Given this list of marker genes Ptprr, Nrp2, Prdm14, Plvap, Il17a, Adora3, Mctp1, Robo1, Apbb1, Furin, Dock10, Il23a, Gipc1, Septin4, Ulk1, Hrg, S100a7a, Ccl21e, Lbp, Rab13, Med23 (NCBI Gene Id 70208), Spint2, Hand2, Dusp22, Tmod3, Tubb4b, Osbpl8, Shh, Jun, Gba1, Vinac1, Ednra, Astn2, Josd1, Rtn4, Vcan, Mstn, Twist1, Aspm, Tekt5, Limd1, Angpt1, Rhoj, C5ar2, Mef2c, S1pr2, Ccl9, Ctnna3, Fut9, Scrib, Ptk2b, Six2, Ttll9, Ephb3, Epha3, Capn7, Spaca9, Mpp1, Fam107a, Cfap44, Kcnq1ot1, Rab1a, Epx, Xcr1, Actn4, Lmna, Il12b, Nrg1, Flna, Hdac6, Daam2, Cadm1, Six1, Iqcn, Tmigd3, Atp7a, Slc26a5, Reck, Fscn1, Trp53inp1, Gnai1, Apc2, Il12a, Prtn3, Fcer1g (NCBI Gene Id 98395), Ephb1, Ssh1, Fpr2, Stc1, Bag4, Apoe, Trp53, Camk2a, P2ry12 (NCBI Gene Id 73058), Catsperd, Ptpn22, S1pr1, Cmklr1, Bsg, Itgam, Bmerb1, Scrt1, Megf9, Rhof (ras homolog family member F (in filopodia)), Scrt2, Stard13, Drc1, Lama3, Ccdc88a, H2bc1, Lyn, Svep1, Cort, Ccl1, Cfap210, Tbx20, Acan, Tekt4 (tektin 4), T, Spp1, Postn, Fbxo41, Pla2g3, Wnt5a, Armc12, Rfx3, Myh10, Barhl1, Cfap221, Vtn, Rap2a, Adam9, Grb10, Cdc42, BC037156, Itgb6, Kif14, Nav1, Trim32, Dnah8, Slc9b2, Tlr4, Acta2, Ptprz1, Tnf, Cdh12, Duoxa2, Il33, Tspo, Acte1, Cfap144, Sema3d (NCBI Gene Id 74345), Setd2, Fut8, Twist2 (twist basic helix-loop-helix transcription factor 2), Irgc, Plcg1 (phospholipase C, gamma 1), Cfap97d1, Rhbdf1, Sgpl1, Smpd3, Atp5f1b, Pik3cd, Nisch, Pkp2, Cfap161, AU040320, Anks1, Sell, Nus1, Epha2 (NCBI Gene Id 13836), Tpgs1, Wasl, Zmiz1, Foxj1, Ccdc125, Rsph1, Tmeff2, Flrt2, Rnh1, Trem2, Acvr1b, Nr2e1, Strip2, Rack1, Dnaja1, Stk39, Ngfr, Ccr9, Stx4a, Emilin1, Adora1, Ribc1, Itgax, Nphp4, Tekt2, Tyro3, Arhgef16, Il6st, Sulf1, Taf7l, Phpt1 (phosphohistidine phosphatase 1), Fgf20, Synj2bp, Igfbp5, Neo1, Itgb8, Ackr2, Ntrk3, Nr4a2, Tafa5, Ccl11 (C-C motif chemokine ligand 11), Plxna1, Gpr173, Gpc4, Adgrb1, Pin1 (peptidyl-prolyl cis/trans isomerase, NIMA-interacting 1), Foxp1, Mylk, Ccl24, Dicer1, Nrtn (neurturin), S2bpcox16, Top2b (topoisomerase (DNA) II beta), Ptprf, Lrg1, Efhb, Dnah10, Foxo3, Amotl1, Hnf4a, Dnaaf6rt, Plxnc1, Kif26a, Zfp703, Ston1, Onecut1 (NCBI Gene Id 52327), Crtam, Pkn2, Megf8, Cep78, P4hb, Elmo2, Nrg3 (neuregulin 3), Prkd2, Fbxo31, Celsr3, Anxa5, B4galt1, Rsph6a, Nexn, Fat1, Dapk2, Emc10, Hsd3b7, Spmip8, Adamts9, Mmp2 (NCBI Gene Id 17390), Arpc2, F11r, Celf3, Rin3, Nr2f1, Dnah12, Fkrp, Dcc, Satb2, Ccl21b, Timp1, Fgfr4, Crkl, Nexmif, Fgf17, Sox10, Atoh8, Usp45, Sun2, Wfdc6b, Barhl2, Itga9 (NCBI Gene Id 70107), Gpc3 (glypican 3), Folr1, Fbxo5, Esr2, Col18a1, Mdga2, Pi4ka, Tie1, Spag6l, Cfap54, Bmp7, Socs7, Cd300a, Retnlg, Cldn5, Itga4, Prm3, Hc, Cfap45, Bdkrb1, Pkn3, Phactr1, Cer1, Axl, Dzip1, Prkca, Vil1 (NCBI Gene Id 22349), Plxnb1, Sirt1, Limch1, Actg1, Ptn, Knstrn, Mmrn2, Cxcl11, Dpep1, Cckar (NCBI Gene Id 12425), Ctnnd1, Mgat3, Pcm1, Actc1, Tek, Zpld2, Hexb, Slit2, Tnr, Kctd13, Asb2, Coro6, Arhgdia, Ntng2, Ptk6, Fndc3b, Dnah2, Gsk3b, Tuba1a, Ext1, Acvr1, Mapt, Ube2i, Cldn13, Sun1, Ptp4a1, Ric8a, Ptprc, Elp6, Nedd9, Jmy, Tesk1, Ptprt, Catsper1, Prkce, Rarres2, Tnfrsf18, Rapgef3, Ppp2r3a, Enah, Retn, Tssk4, Tekt3, Defb47, Fat3, Spmip5, Tpm1, Swap70, Flt4, Ada, Cygb, Ccn4, Mtch2, Eomes, Cldn7, Dydc1, Bst1, Dnaaf4, Alox5, Parva, D130043K22Rik, Myo9b, Spi1, Edn2, Cenpv, Mapk8ip3, Prox1, Il18, Gata2, Rbbp4, Clec14a, Csf1, Ccl19, Unc5c, Vsir, Hmox1, Ddit4, Vstm4, Hhipl1, Adtrp, Bex4, Dusp1, Gnrh1, Ttbk2, Edn3, Adam8, Casp8, Spag9, Ptprk, Nck2, Chst4, Gbf1, Rgcc, Plec, Fermt3, Cfap69 (NCBI Gene Id 207686), Wwc1, Vhl, Fcgr3, Adamts12, Adgra2, Rgn, Spem3, Mir124a-1hg, Srcin1, Tcp11l2, Zfp950, Msx2, Map2k1, Tmf1, Sema5a, Elp3, Sh2b1, Abr, Itga2b, Tubb2a, Pdcl2, Ccdc159, Htr6, Pex2, Gja1, Ajuba, Net1, Cfap126, Cfap95, Rhoa, Defb1, Ogdh (NCBI Gene Id 75674), Filip1, 2610005L07Rik, Map3k7, Ascl2, Il17b, Mir218-2, Cd63, Cripto, Lama4, Sdc1, Dnah6, Abcc8, Dnah11, Usp9y, Coro1a, Cxcr4, Sema4d, Wasf2, Gpx1, Asap3, Shroom2, Tmem18, C2cd6, Dixdc1, Ang6, Vcam1, Vav2, Sh3bp1, Inpp5f, Egfr, Hdac5, Ccl7, Bst2, S100a11, C3ar1, Pik3r1, Spinkl, Lamtor2, Camk2b, Stat5b, Pcnt, Mien1, Fadd, Plcg2, Mdga1, Clasp2, Paxip1, Pcsk5, Sdc3, Itgb7, Ribc2, Mmp28, Smim22, Hoxa7, Tlr2, Fgf21, Ttll6, Brms1l, Mark1, Mkks, Gp1ba, Fgf13, Wdr47, Tjp1 (tight junction protein 1), Ppbp (pro-platelet basic protein), Egr3, Myadm, Gm6040, Prcp, Cxcl3, Cfap43, Sema4g, Abhd6, Rras, S100a14, Ephb4, Tnfsf18, Slamf9 (SLAM family member 9), Tet1, Rabl2, Plau, Ppib, Syne2, Tfap2a, Tns3, Foxf1 (NCBI Gene Id 15227), Muc2, Fscn2, Hif1a, Wt1, Chga, Ndnf, Lrrc15, Slc9b1, Rhox5, Dab2, Cfl1, Kiss1, Cdk5r2, Cpeb1, Spmip6, Anln, Drd2, Grb7, Gdf15, Diaph1, Cspg4, Phactr4, Serpine1, Sin3a, Acp5 (acid phosphatase 5, tartrate resistant), Saa3, Nme8, Ecm1, Eng, Smo, Sirpa, Srgap1, Mtus1, Cacna1e, Catsper3, Ggt5, Src, Mcu, Tssk6, Nog, Ttll3, Coro7, Enpep, Prl7d1, Fgf16 (fibroblast growth factor 16), Patz1, Fhad1, Fignl2, Vdac3 (voltage-dependent anion channel 3), Cyp19a1, Ly6k, Spns2, Dlg5, Dnai1, Tnn (NCBI Gene Id 329278), Arc, Gsk3a, Apex1, Wdr62, Ntf3, Cers2, Smcp, Cfap251, Apod, Peak1, Fgf22, Mmp14, Arhgef5, Ezh2, Klf4, Tmprss12, Cdh13 (NCBI Gene Id 74373), Ptpru, Rbbp7, Pak1, Nsmf (NMDA receptor synaptonuclear signaling and neuronal migration factor), Insl3, Lama5, Aif1, Phb2, Robo4, Macf1, Pdgfb, Lgmn, Arid2, Mdm2, Spem1, Mysm1, Calr, Gas6, Cd44, Insm1, Defb5, Nav3, Ccr5, Vcl, Frmd5, Synpo2, Pou4f1, Fyn, Hdac4, Hmgb2, Fgf4, Cdh23, Ccl19-ps5, Bambi, Tnc, Xcl1 (chemokine (C motif) ligand 1), Akt2, Mir218-1, Cd2ap (CD2-associated protein), Cdh17, Drd5 (NCBI Gene Id 13492), Arx, Fut10, Stat5a, Ddx4, Lmo4, Ccl19-ps4, Pparg, Ccdc146, Pgr, Oxsr1 (NCBI Gene Id 72172), Pmp22, Spred1, Lima1, Ift81, Ndrg4, Tgfb2, Appl1, Gpr15, Pbxip1, Pithd1, Sema4c, C5ar1, Sema4b, Lamb2, Lemd3, Plxnd1, Fgf1, Pde4b, Syde2, Arhgap18, Dync2h1, Catspere1 (NCBI Gene Id 631584), Pex5, Fgf2, Hoxa5, Rap2b, Fut4 (NCBI Gene Id 14345), Chst2, Nup85, Cttn (cortactin), Hyal1, Nhlh2, Stap1, Ier2, Tnfsf14, Rnf41, Slc22a16, Tnfsf4, Nr2f2, Mapk3, Tmem201, Mns1, Angpt2, Cdh10, Ednrb, Prkcq, Six3, Pomgnt2, Sstr4, Ccar1, Clec7a, Prkx, Rhod, Gna13, Fmn2, Cck, Flt1, Cfap141, Kdr, Tgfbr3, Clrn1, H1f6, Il17rc, Lypd4, Plpp3, Spef1, Mcam, Onecut2, Scg2, Fas, Myo1f, Hes1, Hbegf, Nck1, Cyp1b1, Ackr3, Large1, Fgf10, Fpr-rs3, Hmgb1, Spry2, Adcy3, Jag1, Chrna7, Acap3, Gm28729, Cdh18, Atn1 (atrophin 1), Efemp1, Ccl21a, Amotl2, Wdpcp, Nckap1l, Ccl17, Plcb1 (phospholipase C, beta 1), Mcoln2 (mucolipin 2), Cfap276, Arid5b, Vegfd, Lpxn, Clasp1, Il1a, Insr, Cav1, Lratd1, Cfap68, Bbs1, Cxcr5, Map3k1, Rigi, Arhgap24, Cib1, Tekt1, Nme5, Gpc1, Saxo4, Pld1, Ackr4, Fgf8, Nde1, Tac2, Dnah3, Kiss1r, Ccr1, Dpcd, Fut1 (NCBI Gene Id 14343), Fstl1, Fam83h, Hdac1, Ccbe1, Ttc12, Actb (actin, beta), Evx1, Cfap119 (NCBI Gene Id 233899), Ifng, Dubr, Rabgef1, Anxa1, Pawr, Gpr35, Mark2, Tacr1, Cldn19, Dbh, Mrtfa, Gab1, Fga, Lyve1, Zswim6, Sap130, Akirin1, Eno4, Ninj1, Rasgef1a, Drd1, Cfap157, Marveld3, Cxadr, Ntn1, Pdcd10, Klrk1, Lrp1, Wnt5b, Zfand5, Gfra1 (glial cell line derived neurotrophic factor family receptor alpha 1), Eppin, Prpf40a, Acvrl1, Edn1, Cd99l2, Hspa5, Pds5a, Abl2, Gpr18, Lcn2 (lipocalin 2), Gper1, Rras2, Mapk15, Gata3, Rsph3b, Odad3, Bax, Prr5l, Mdk, Tmigd1, Spock1 (sparc/osteonectin, cwcv and kazal-like domains proteoglycan 1), Sema4a, Tert, Igf2, Ror2, Gp2, Ogt, Pdgfc, F2rl1, Myd88, Fgfr1 (NCBI Gene Id 14182), Gpc6, Brk1, Smad3, Hras, Cul3, Drd4 (NCBI Gene Id 13491), Drc7, Crk, Sdcbp, Tmem102, Adgrg1, Plxna4, Myo1c, Dcaf17, Ccl8, Angpt4 (NCBI Gene Id 11602), Ets1, Alkbh1, Igf1, Nf1, Sox18, Astn1, Mesp1, Cdh5, Sbp, Cd200r1, Rapgef4, Cxcl5, Myo1g, Nr4a3, Atp2b4, Sox1, Gnai2, Cfap53, Acvr1c, Sema3b, Fpr-rs4, Ndel1, Arid4b, Selp, Smarca4, Dach1 (NCBI Gene Id 353035), Rdx, Anxa3, Spag8, Ripor2, Elmo3, Apbb2, Scnn1b, Gk2, Plp1, Sod2, Pfn4, Foxe1, Nfe2l2, Dchs1, Map2k3, Cntn2 (contactin 2), Itga3, Prkcz, Strbp, Ccn1, Ltb4r2, Ano6, Rac1, Ch25h, Lrrk2, Mapre1, Neurog2, Slit1, Ccl19-ps1, Slc37a4, Garin5a, Crb2, Fsip1 (NCBI Gene Id 75478), Sord, Lama2, Apcdd1, Cd74, Micall1, Syk, Sdccag8, Lhx6, Rnf7, Ang4, Jagn1, Il16, Cxcr6, Cfap90, Tppp2, Fer, Kirrel3, Sema3g, Jaml, Itga7 (integrin alpha 7), Appl2, Rac2, Dmrt1, Stat3, Cx3cl1, Wfdc6a, Arpc5l, Abi2, Sec1, Arhgef7, Myo5a, Prr5, Selenok (NCBI Gene Id 80795), Dusp21, Prl2c2, Ppia, Pld2, Myc, Gna12, Tgfbr2, Sox17, Cdh20, Fuz, Tlx3, Vegfa (vascular endothelial growth factor A), Stmn1, Sh3kbp1, Trip6, Mmp1a, Cep131, Cdh4, Mia3, Gpi1, Rps6kb1, Sema3f, Fn1, Dnah7c, Gcnt2, Mst1, Rpl13a, Tnfaip1, Iqcf1, Rhog, Plekho1, Duox1, Adam10, Dab2ip, Slc9c1, Ctsh, Fgf18, Vps13a, Hgf, Cfap20, Krit1, Ldb2, Rbfox2, Sema4f, Igfbp6, Ret, Ift88, Il34, Map4k4, Csf2, Braf, Ace, Cdh8, Kit, Il4, F7, Camk2d, Cdh1, Jcad, Rab11a, Lefty1, Ripk3, Vav3, Fermt2 (fermitin family member 2), Pdlim1, Ythdf3, Trpm4, Dab1, Creb3, Sorl1, Tacr2, Lpar1, Ppard, Mink1, Ptprb, Aimp1, Hdac9, Coro1b, Ddrgk1, Actr3, Pip5kl1, Cdk5r1, Ptafr, S100a8, Dysf, Dll4, Mrtfb, Igfbp3, Eps8, Misp, Armc3, Sox9, Meig1, Gpsm3, Ppp3ca, Tubgcp2, Fmnl1, Trim55, Epcam, Perp, Trem3, Sdc4, Foxn1, Arhgdib, Arhgef39 (NCBI Gene Id 230098), Cdk5, Vangl2, Nars1, Lrp8, Macir, Ptprj, Gfra3, Gpm6a, Efcab9, Amot, Trpm2, Ropn1l, Gadd45a, Tnfrsf12a, Tbc1d21, Lgals9, Suds3, Rffl, Stk4, Ccl19-ps6, Ttll8 (NCBI Gene Id 75652), Pdcd6, Prex1, Pde4d, Pf4, Nbl1, Adgrl3, Cxcr3, Gpnmb, Maz, Sp1, Ascl1, Ssx2ip, Sema6b, Iqub, Fgf7, Defb33, Usp17le, Cimap1a, Pik3ca, Sfrp2, Pip5k1a, Vash1, Phox2b, Lamb1, Pikfyve, Atp8a1, Dnm1l, Smoc2 (SPARC related modular calcium binding 2), Flt3, Fgf3, Zp3, Bmp10, Arsb, Pik3c2g, Fam3d, Ptger4, Ppargc1a, Svbp, Mitf, Tac1, Defb3, Lama1, Bmpr2, Gpc5, Specc1l, Iqsec1 (IQ motif and Sec7 domain 1), Fbn2, Erdr1, Podxl, Lrp5, Podn, Schip1, Ptp4a3, Ptprm, Ccl26, Nr4a1, Nsun7, Sst, Eppk1, Ccl4, Mixl1, Enpp2, Agr2, Col3a1, Fermt1, Cdh26, Pik3cg, Pacrg, Has1, Cldn4, Sbds, Bcl11b, Nkx2-1, Ccdc40, Dnaaf6, Bcl2, Rhox8, Thy1, Defb25, Plat, Ptk2, Cbll1, Ash1l, Mir504, Lrch1, Itga5, Htr2b, Efcab6, Actbl2, Ehd4, Zmynd12 (NCBI Gene Id 332934), Alox12, Tubb2b, Itga2, Pdgfrb, Wincr1, Itgb4 (integrin beta 4), Lep, Defb46, Fpr-rs7, Itgb1bp1, Dclk1, Ttc21a, Spag16, Rock2, Catsper4, Dnah7b, Abcc1, Smad2, Tor1a (torsin family 1, member A (torsin A)), Snai2, Hcls1, Foxo4, Usp9x, Agtr1a, Rsph9, Cxcl15, Defb8, Bin2, Palld, Arhgap35, Tbxa2r (thromboxane A2 receptor), Cabcoco1, Scai, Atp5f1a, Itgav (NCBI Gene Id 76358), Adam17, Lcp1, Tac4, Ropn1, Fzd3, Zeb2, Csf1r, Apc, Rps19, Slamf8, Gm266, Il1r1, Neurl1a, Nfatc2, Scnn1g, Tex101, Slc12a2, Rreb1, Fut7, S100a2, Map2k5, Cthrc1, Robo3, Cadm4, Arf4, Selplg, Cd47, Matn2, Meak7, Mmp9, Carmil2 (capping protein regulator and myosin 1 linker 2), Fap, Myh9, Ffar2, Egfl7, Drgx, Insl6, Grn, Add2, Fat2 (NCBI Gene Id 245827), Bmp2, Trim46, Efhc2, Enkur, Was, Ccl6, Cd34, Tacstd2, Dusp10, Catsper2, Wdr1, Pak2, Ccr4, Jup, Mcur1, Ctnnb1, Hyal2, Pik3cb, Apob, Fktn, Nos3, Cxcl2, Katna1, Ldb1, Cd177, Cklf, Gm5849, Unc5d, Cxcl1, Fgf9, Itgb2l, Ing2, Fgf15, Fgfbp1, Adgrg3, Dst, Mmp3, Itga11, Fmnl2, Glipr2, Cend1 (NCBI Gene Id 80544), Hspa12b, Gbx2, Efnb1, Dapk3, Ang5, Bbs4, Cdh2, Ldlrad4, Pltp, Fam89b, Arhgap5, Prop1, Mapk8, Defb4, Arf6, Srpx2, Atp1a4, Ttll5, Ago2, Tnfsf11, Mnx1, Pax6, Plxna3, Pdpn, Arhgef2, Bves, Rin2, Ccr10, Cdc42bpb, Snai1, Cdc42bpa, Atp1b2, Vegfb, Dcn, Tiam1, Myocd, Pdgfra, Or4m1 (NCBI Gene Id 258658), Cldn1, Cdh6, Cabs1, Pafah1b1 (NCBI Gene Id 94322), 4930544G11Rik, Epha4, Cd24a (CD24a antigen), Pin1rt1, Tektl1, Myo10, Pcdha9, Bin3, Cap1, Tnfaip3, Cavin1, Gpld1, Reln, Duox2, Slurp1, Sbpl, Cfap107, Tirap, Ccdc141, Pfn1, Afdn, Ccrl2, Epb41l4b, Tafa4, Nox1, Megf10, Fes, Ang (NCBI Gene Id 11727), Naca, Cdh22, Ccr7, Garin3, Ccl2, Ptprg, Lgr6, Ing1 (NCBI Gene Id 69244), Tcaf1, Slc8b1, Dnhd1, Bmper, Abl1, Capn1, Defb6, Foxc2 (NCBI Gene Id 14234), Scn11a (NCBI Gene Id 24046), Adam15, Pvr, Rock1, Egf, Ovol2, Ppm1f, Plk2, Nodal, Adarb1, Usp33, Tpbg, Cd200, Abi3, Ptpro, Nfix, Garin5b, C1qbp, Kcnn4, Tgfbr1, Pten, Ifnb1, Zfp609, Has2 (hyaluronan synthase 2), Cdkl5, Lamb3, Pik3c2b (NCBI Gene Id 240752), Itga6, Cimip2a, Dock4, Pik3c2a, Adora2b, Jam3, Cnn2, Sp100, Gsx2, Kif20b, Fsip2, Catsperz, Sox14, Bmp4, Arpc5, Rac3 (NCBI Gene Id 170758), Pitx2, Pxn, Notch1, Cfap47, Cox7b2 (cytochrome c oxidase subunit 7B2), Lztfl1, Sema3c, Fam110c, Stk10, Phldb2, Sox8, Cass4, S100a9, Ccr3, Ssh2, Mapk1, Cd274 (NCBI Gene Id 60533), Pou3f2, Gli1, Il24, Aqp1, Cd40 (CD40 antigen), Cd9, Cimip2c, Cxcl17, Pax3, Il17ra, Ccdc25, Il1b, Col1a1, Mmp10, Pycard (PYD and CARD domain containing), Sema6d, Pdgfd, Arhgap32, Abi1, P2ry1, Map2k2, Sh3d21, Bcas3, Lox, Garin2, Spata13 (spermatogenesis associated 13), Adipor1, Meox2, Nup62, Tektip1 (NCBI Gene Id 432479), Spag6, Sinhcaf, Cyp7b1, Dnah14, Tbccd1, Cfap58, Ptgs2, Lmx1b, Thbs4, Cep128, Ap1ar, Ddr2, Myoc, Plaa, Defb14, Icam1, Ccl20, Ppp1r9b, Poc1b, Clxn, Defb37, Txndc2, Plxnb3, Prkcd, Camk1d, Tgfb1, Dock7, Lrp6, Ccl3, Mmp12, Apoa1, Dag1 (dystroglycan 1), Plekhg3, Dpysl3, Pfn2, Dlc1, Fam83d, Gli3, Trib1, Disc1, Nlrp3 (NCBI Gene Id 216799), L1cam, Hspb1, Rufy3, Hace1, Ptk7, Nckap1, Ccl19-ps3, Ntng1, Dnajb13, Iqgap1, Adam3, Slk, Il27ra, Bbs2, Rab25 (NCBI Gene Id 99846), Elane, Uts2, Adra2a, Fezf2, Elp5, F3, Pex13 (peroxisomal biogenesis factor 13), Serpinf1, Miip, Csf3r, Tns1, Cxcl9, Cdh11, Prickle1, Krt16, Lamc1, Tmsb4x, Lypd3, Apoh, Lrig2, Fam114a1, Dnah5, Ifitm1, Sh3rf1, Mta2, Six4, Zmynd10, Mmp7, Emilin2 (elastin microfibril interfacer 2), Adamts1, Dock1, Klc3, Cxcl13, Nrp1, Gapdhs (NCBI Gene Id 14447), Or51e2, Chrd, Sash1, Krt5, Dock2, Nherf1, Celsr2, Akap12, Gcnt1, Dcx, Madcam1, Unk, Prkci, Arl13b, Wwc2, Abhd2, Plet1, Cd151, Srgap2, Errfi1, Zmynd8, Zranb1, Cdhr18, Ceacam1, Grin1, Fpr-rs6, Sh3rf2, Cep85, Pik3r2, Grem1, Ift46, Sin3b, Septin14, Spef2, Artn, Zfp640, Itgbl1, Srgap3, Efhc1, Ccdc65, Efnb2, Il1rn, Dnai3, Cx3cr1, Fbxw7 (NCBI Gene Id 68467), Ccl22, Ccl21d, Kif9, Lhx1, Pdpk1, Igsf10, Cep85l, Tbx1, Tcte1, Tmem196, Gstp1, Spmip9, Rnf20, Gdf6, Fubp1, Lrriq1, Cnr2, Rhoc, Fgf23, Itgb2, Rnase9, Carmil1 (NCBI Gene Id 68732), Pml, Mesp2 (mesoderm posterior 2), Srf (serum response factor), Akap4, Ankrd11, Mcc, Ccl21f, Mtor, Isl1 (NCBI Gene Id 16392), Cfap52, Pierce1, Ccl25 (C-C motif chemokine ligand 25), Adipoq, Ripor1, Egr1, Ccn3, Ints13, Shtn1, Rsph14, Nipbl, Cdh19, Ccn2, Gas8, Csnk2b, Tmsb15b2, Pla2g7 (NCBI Gene Id 98095), Itgb3, App, Nlrp12, Mst1r, Cdh15, Kif2a (NCBI Gene Id 319353), Dreh, Coro1c, Cep43, Cln3, Efna1, Plxnb2, Igf1r, Trpv4, Evl, Rap2c, Trf (NCBI Gene Id 22041), Mertk, Dpp4, Cpne3, Pdilt, Rcc2, Fbxo45, Ager, Flrt3, Dnaja4, Cyrib, Sele, Qrich2, Smurf2, Ctsg, Sema7a, Gtpbp4, Plg, Tsc2, Bmpr1a, Nkx6-1, Slamf1, Ulk4, Pkn1, Hsp90aa1, Ptpn11, Xbp1, Cfap70, P2rx4 (NCBI Gene Id 52272), Zc3h12a, Akt3, Nme7, Fgf6, Hdac2, Spn, Atm, Cfap57, Kank2, Gpr15lg, Cd81, Smad4, Mapre2, Arhgap4, Bex6 (brain expressed family member 6), Ptpn1, Cfap65, Ntrk2, Gpc2, Slc8a1, Thbs1, Tnp2 (NCBI Gene Id 21959), Ctnna2, Cxcl16, Hoatz, Lrp12, Ang2, Glul, Spmip10, Col5a1, Dsg3, Cdkn1b (cyclin dependent kinase inhibitor 1B), Enpp1, Sap30l, Depdc1b, Nkx2-3, Itgal, Foxc1, Nanos1, Carmil3, Dnaaf2, Sema5b (NCBI Gene Id 20357), Aoc3, Plekhg5, Aire, Cxcr1, Erbb4, Gfus, Vax1, Pgk2, Vrk1, F2r, Lrrc23, Iqcg, Psen1, Tnfaip6, Yif1b, Myo18a, Lyst (NCBI Gene Id 217998), Ddit3, Fbln1, Umod, Agt, Nox4 (NADPH oxidase 4), Spata33, Gstp2, Ccnyl1, Gdnf, Atoh1, Vegfc, Dnah1, Lgals8, Bbof1, Foxg1, Pldi, Itga1, Tbc1d24, Cdh7, Fmnl3, Prkg1, Epha1, Emp2, Celsr1, Tnp1, Akap3, Slc22a14, Dnah7a, Fzd4, Rsph4a (NCBI Gene Id 212892), Cul5, Rapgef2, Foxb1, Ccr2, Auts2, Angptl3, Met, Tmsb15b1, Prag1, Cd69, Wnt11, Dock5 (NCBI Gene Id 68813), Epb41l5, Vim, Clic4, Hdac7, Zfp580, Golph3, Ptger3, Mir875, Defb48 (NCBI Gene Id 432867), Dstn, Sema3a, Tmsb15a, Osgin1, Magi2, Srp54a, Dmtn, Itgb1, Idh2, Dnah17, Lrrc46, Pak3, Tmem232 (transmembrane protein 232), Podxl2, P2ry2, Apela, Cldn3, Ccl28, Tmsb10, Dusp3, Ccl12, Bcl6, Ccr8, Irak4, Ndn, Krt2, Gab2, Plxna2 (NCBI Gene Id 98694), Tbx5, Hoxb9, Lamc2, Prss37, Tgfbr3l, Arrb2 (NCBI Gene Id 216869), Mif, Scarb1, Kitl, Slirp, Aldoa, Sap30, Igsf8, Cited2, Tff2 (trefoil factor 2 (spasmolytic protein 1)), Trem1, Efs, Numb, Lgals3, Ctnna1, Adam7, St3gal4, Pacsin2, Sparc (secreted acidic cysteine rich glycoprotein), Ccdc38, Gdf2, Vav1, Dnali1, Fezf1, Cxcl12, Wnk1, Ntn4, Inpp5b, Ccr6, Olig3, St14, Stk24, Map3k3, Radil, Brms1, Sdc2, Irs2, Chl1, Jam2, Ddr1, Ccl27a, Dnah9, Defb7 (NCBI Gene Id 246080), Fscn3, Tradd, Mmrn1, Ttll1 (NCBI Gene Id 319953), S100a11-ps, Rere, Elmo1, Ccl5, Park7, Ephb2, Lef1, Padi2, Brat1, Nod2, Syde1, Mecp2 (methyl CpG binding protein 2), Wnt7a, Dcdc2a, Ldhc, Sema6c, Agtr1b, Catspere2, Cd248, P2ry6, Fgf5, Emx2, Pierce2, Armc2, Pard3, Akt1, Adipor2, Tbx21, Mgat5 (NCBI Gene Id 98381), Neurod4, Sphk1, Msmp, Cfap61, Arid4a, Sema3e, Pecam1, Ube2b, Rnase10, Cdh9, Camsap3, Arpin, Sema6a, Bcr, Tnfrsf14, Fgr, Pex7, Mboat7, Loxl2, Pou3f3, Tacr3, Dnaaf11, Rhob, Mospd2, Card10, Cimip2b, Pdgfa, Cxcr2, Pgf, Spdl1, Ptpn23, Gpr183, Misfa, Msn, Ywhae, Cdh24, Jak2, Cfap206, Ccdc39, Wdr44, Avl9, Ccr1l1, Cdh3, Gcsam, Phlda2, Irs1, Cxcl10, Cxcl14, Cemip, Prss55, Lurap1, Itgb5, Dock8, Prkd1, Pik3r3, Wnt4, Kank1, Gas2l2, Epha8, Ilk, Sfrp1, Bcar1, Stk26, here is a description of the gene set: Mouse Gene Set: GOBP_CELL_MOTILITY Any process involved in the controlled self-propelled movement of a cell that results in translocation of the cell from one place to another. species: Mus musculus